The following is a description of a gene set: A G protein-coupled receptor signaling pathway in which the signal is transmitted via the activation of phospholipase C (PLC) and a subsequent increase in the intracellular concentration of inositol trisphosphate (IP3) and diacylglycerol (DAG). IP3 regulates the opening of calcium channels in intracellular calcium store, leading to the release of calcium into the cytosol. Calcium and DAG activate protein kinase C (PKC), which in turn activates downstream effectors. Mouse Gene Set: GOBP_PHOSPHOLIPASE_C_ACTIVATING_G_PROTEIN_COUPLED_RECEPTOR_SIGNALING_PATHWAY studied in species Mus musculus, and this is the list of marker genes: Adra1b, Ano1 (anoctamin 1, calcium activated chloride channel, NCBI Gene Id 233978), Dgkh, Bdkrb1, Trpc1, Lrp1, Tgm2, Ednrb, C5ar1, Fpr-rs6, Nherf1, Dgkg, Htr2c, Ms4a2, Orai1, Hcrtr2, Nmur1, Mc1r, Fpr1, Pth1r, Fpr-rs7, Htr1b, P2ry1, Adgrg1, Galr2, Oprm1, Gpr33, Adra2a, Fpr-rs3, Trhr2, Stim1, Fpr2, Oprl1, Gpr143, Wnt5a, Lpar1, Gna15, C3ar1, Gpr55, Hcrt, Dgkq, Drd4, Plek, Prkd1, Htr2b, Drd3, Abl2, Cmklr1, Vegfa, Plcb4, Dgki, Nmur2, Dgkb, Edn2, Ptafr, Plcb2, Gnb1, Agtr1b, Gpr27, Adra1d, Chga, Adora2a (adenosine A2a receptor), Vmn2r81, Ffar4, Pick1, Trhr, Cck, Fshr, F2, Grid1, Plce1, Inpp5a, Oprd1, Rxfp3, Actn2, C5ar2, Cxcr2 (NCBI Gene Id 12765), Gna11, Dgke, Anxa7, Ednra, P2ry2, Ffar1, Prkcg, Plcd1, Prkd3, Dgkd, Plcb3, Ffar2, Cx3cr1, Npr3 (natriuretic peptide receptor 3), Gng13, Ptger3, Il2, Gpr83, Bicd1, Agtr1a, Pik3cg, Oprk1, Lhcgr, Fpr-rs4 (NCBI Gene Id 14291), Prkcb, Crhr1, Kiss1, Gpr157, Taar1, Grpr, Htr2a, Grm5, Adra1a, Grp, Rasgrp4, Grm1, Drd1, Esr1, Cckbr, Dgka, Ntsr2, Dgkz, Edn1, Gna14 (guanine nucleotide binding protein, alpha 14), F2r, Casr, Itpr1, Gnaq, Gpr139, Plch2, Plcb1 (phospholipase C, beta 1), Drd2, Prkd2, Sele, Mas1, Crhr2, P2ry12, Myh9, Fpr3, S1pr1, Avpr1b, Gpr4, Chrm3